Given this list of marker genes PEX6, ABCD1, AMACR, BCAP31, AP1S1 (adaptor related protein complex 1 subunit sigma 1), REPS1, PEX2, PEX12, PEX14, HSD17B4, here is a description of the gene set: studied in species Homo sapiens Human Gene Set: HP_INCREASED_CIRCULATING_VERY_LONG_CHAIN_FATTY_ACID_CONCENTRATION Increased concentration of very long-chain fatty acids in the blood circulation. Very long-chain fatty acids are fatty acids (FAs) with a chain-length of 22 or more carbons. Increased circulating very long-chain fatty acid concentration